Given this list of marker genes 2810001G20Rik, Mxd1, Dennd5a, Lyst, Usp27x, Fgd6, Cyp2s1, Inafm2, Ttc39b, Ppic, Gsta4, Fam89a, Tmem64, Dst, Ikzf4, App, Rnf32, Bmpr2, Emp1, Mtmr3, 4930431P03Rik, Dnah12, Hs3st3b1, Lrrc8d, Specc1, Map6, Tmem158, Klrd1, Amigo2, Itih5, Rgcc, Tnfrsf13b, Pdlim4, Ecm1, Anxa1, Jun, Appl2, D630039A03Rik, Enpp1, Hipk2, Ifitm3, Prnp, Xkrx, Prf1, Actn1 (actinin, alpha 1), Tmsb10, Fos, Msra, Ift80, Drc1, St3gal6, Sostdc1, Il10, Adamts6, Selp, Galm, Tlr7, Trub1, Qpct, Gata1, Agpat4, Afp, Arhgap20, Abcb1b, Ntrk3, Enc1, Gzmk (NCBI Gene Id 14945), Ncoa7, Igf2r, Gm3696, Nt5e, Pard6g, Glipr2, Gramd2b, Kcnk6, Socs2 (NCBI Gene Id 216233), Cyfip1, Snn, Gucy1a1, Fasl, Wls, Apobr, Resf1, Ahcyl2, Ldlrad4, She, Eno3 (NCBI Gene Id 13808), Hectd2, Mbnl3, Rabgap1l, Evi2a, Gbp2b, Prg4, Myo1e, Ppp1r3e, here is a description of the gene set: studied in species Mus musculus Regulatory CD4+ T cells (Tr cells), the development of which is critically dependent on X-linked transcription factor Foxp3 (forkhead box P3), prevent self-destructive immune responses. Despite its important role, molecular and functional features conferred by Foxp3 to Tr precursor cells remain unknown. It has been suggested that Foxp3 expression is required for both survival of Tr precursors as well as their inability to produce interleukin (IL)-2 and independently proliferate after T-cell-receptor engagement, raising the possibility that such 'anergy' and Tr suppressive capacity are intimately linked. Here we show, by dissociating Foxp3-dependent features from those induced by the signals preceding and promoting its expression in mice, that the latter signals include several functional and transcriptional hallmarks of Tr cells. Although its function is required for Tr cell suppressor activity, Foxp3 to a large extent amplifies and fixes pre-established molecular features of Tr cells, including anergy and dependence on paracrine IL-2. Furthermore, Foxp3 solidifies Tr cell lineage stability through modification of cell surface and signalling molecules, resulting in adaptation to the signals required to induce and maintain Tr cells. This adaptation includes Foxp3-dependent repression of cyclic nucleotide phosphodiesterase 3B, affecting genes responsible for Tr cell homeostasis. Mouse Gene Set: GAVIN_FOXP3_TARGETS_CLUSTER_P7 from publication Gavin MA, Rasmussen JP, Fontenot JD, Vasta V, Manganiello VC, Beavo JA, Rudensky AY (PMID 17220874) Cluster P7 of genes with similar expression profiles in peripheral T lymphocytes after FOXP3 loss of function (LOF).